The following is a description of a gene set: Increased Myc gene copy number is observed in human prostate cancer. To define Myc's functional role, we generated transgenic mice expressing human c-Myc in the mouse prostate. All mice developed murine prostatic intraepithelial neoplasia followed by invasive adenocarcinoma. Microarray-based expression profiling identified a Myc prostate cancer expression signature, which included the putative human tumor suppressor NXK3.1. Human prostate tumor databases revealed modules of human genes that varied in concert with the Myc prostate cancer signature. This module includes the Pim-1 kinase, a gene known to cooperate with Myc in tumorigenesis, and defines a subset of human, Myc-like human cancers. This approach illustrates how genomic technologies can be applied to mouse cancer models to guide evaluation of human tumor databases. from publication Ellwood-Yen K, Graeber TG, Wongvipat J, Iruela-Arispe ML, Zhang J, Matusik R, Thomas GV, Sawyers CL (PMID 14522256) Mouse Gene Set: ELLWOOD_MYC_TARGETS_UP Genes up-regulated in transgenic mice expressing human MYC in prostate. species: Mus musculus, and this is the list of marker genes: Pigk, Ece1, Rgs19, Hsd17b12, Sprr2a1, Bag2, Rpl37a, Spats2, Ly6d, Uck2, Ppp1r18, Ccdc93, Dpp7, Ly6a, Clcn1